Given this list of marker genes MCCC2, AUH, HMGCLL1, MCCC1, BCKDK, IVD, HMGCL, here is a description of the gene set: Human Gene Set: GOBP_L_LEUCINE_CATABOLIC_PROCESS The chemical reactions and pathways resulting in the breakdown of L-leucine, 2-amino-4-methylpentanoic acid. species: Homo sapiens